Given this list of marker genes SPTLC2, ATL3, SPTLC1 (serine palmitoyltransferase long chain base subunit 1), NTRK1 (neurotrophic receptor tyrosine kinase 1), ATL1, here is a description of the gene set: Human Gene Set: HP_TROPHIC_CHANGES_RELATED_TO_PAIN Trophic changes is a term used to describe abnormalities in the area of pain that include primarily wasting away of the skin, tissues, or muscle, thinning of the bones, and changes in how the hair or nails grow, including thickening or thinning of hair or brittle nails. species: Homo sapiens Trophic changes related to pain